Given this list of marker genes NEIL3, here is a description of the gene set: part of: Diseases of Base Excision Repair species: Homo sapiens NEIL3 is a DNA N-glycosylase involved in base excision repair (BER), the primary repair pathway for oxidative DNA damage. NEIL3 can detect and remove oxidized guanine, in the form of 5-guanidinohydatoin and spiroiminodihydantoin, and oxidized thymine, in the form of thymine glycol. NEIL3 has a preference for single strand DNA (ssDNA) and is implicated in repair of oxidative DNA damage at telomeres. A NEIL3 disease variant NEIL3 D132 is unable to cleave 5 guanidinohydantoin (Gh) from oxidatively damaged DNA. Individuals harboring a NEIL3 D132V homozygous mutation are predisposed to development of autoimmune diseases and NEIL3 depletion is also associated with an increase in telomere damage and loss. NEIL3 unhooks DNA interstrand cross-links (ICLs) during DNA replication. NEIL3 resolves psoralen- and abasic site-induced ICLs in a Fanconi anemia (FA) pathway-independent manner.<br>A polymorphism in one of the NEIL3 gene splice sites may increase the risk of myocardial infarction. NEIL3 expression in the heart increases after heart failure in humans and after myocardial infarction in mouse disease models. Neil3 knockout mice show increased mortality after myocardial infarction, but there is no increase in the amount of DNA damage in Neil3 knockout hearts. In the heart, NEIL3 may function in the epigenetic regulation of gene expression and facilitate transcriptional response to myocardial infarction. NEIL3 mRNA expression is increased in human carotid plaques and Neil3 deficiency accelerates plaque formation in Apoe knockout mice, but it appears that this is not correlated with oxidative DNA damage.<br>The function of NEIL3 in removal of hydantoins from single strand DNA may be important for removal of replication blocks in proliferating cells. Mouse embryonic fibroblasts and neuronal stem cell derived from Neil3 knockout mouse embryos show decreased proliferation capacity and increased sensitivity to DNA damaging agents. NEIL3 may be required for maintenance of adult neurogenesis, as Neil3 knockout mice exhibit learning and memory deficits and synaptic irregularities in the hippocampus. In addition, NEIL3 deficient neuronal stem cells exhibits signs of premature senescence and Neil3 knockout mice show reduced ability to augment neurogenesis to repair damage induced hypoxia ischemia.<br>Mice that are triple knockout for Neil1, Neil2 and Neil3 do not show a predisposition to tumour formation or changes in telomere length.<br> Reactome Pathway: Defective Base Excision Repair Associated with NEIL3